The following is a description of a gene set: Clonal hematopoietic stem cell disorders characterized by dysplasia (ineffective production) in one or more hematopoietic cell lineages, leading to anemia and cytopenia. Myelodysplasia Human Gene Set: HP_MYELODYSPLASIA studied in species Homo sapiens, and this is the list of marker genes: CEP57, HSPA9, GATA1, BLM (BLM RecQ like helicase), LIG4, SRSF2, SAMD9L, UBA1, RPS27, RPS26, THPO (NCBI Gene Id 84434), DDX41, RPL35A, ASXL1, ICOSLG, H4C9, JAK2, FANCC, SF3B1, ADH5, FANCM, FANCA, BUB1B, BUB1, DKC1, ERCC4, RUNX1, RPL9, RPL8, RPS14, WRN, MAD2L2, FANCE (NCBI Gene Id 2178), RPA1, ATRX, ANAPC1, ADA2, FANCF, EFL1, MPL, SLX4, CDKN2A, CHEK2, RPS19, SBDS, TCIRG1, RPL5, CSF3R, RAF1, BRCA1, SRP72, BRIP1, XRCC2, FANCB, RPL31, NF1, RPS15A, RECQL4, GNB1, RPS29, HSCB, HEATR3, RPL35, RPL11, RPS7, GINS1, TET2, FANCL, BRCA2, RPL27, MYSM1, BUB3, FANCG, FANCI, NAF1, RPS24, FANCD2, BRAF (NCBI Gene Id 673), GFI1 (NCBI Gene Id 2672), UBE2T, PALB2, CLPB, HAX1, RPL26, SMARCD2 (SWI/SNF related, matrix associated, actin dependent regulator of chromatin, subfamily d, member 2), ERBB3, RPS20, TINF2, GATA2, ELANE, RAD51, SH2B3, RPS17, PTPN11 (protein tyrosine phosphatase non-receptor type 11), TERC, SRP54, MDM2, KIT, NBEAL2, RPS28, NAGS, SRP19, TERT, RPL15, CALR, RAD51C, RPL18, TP53, RFWD3, RPS10, SAMD9 (NCBI Gene Id 54809), DNAJC21, TRIP13, TSR2